The following is a description of a gene set: CD8+ T cells play a crucial role in the clearance of intracellular pathogens through the generation of cytotoxic effector cells that eliminate infected cells and long-lived memory cells that provide enhanced protection against reinfection. We have previously shown that the inhibitor of E protein transcription factors, Id2, is necessary for accumulation of effector and memory CD8+ T cells during infection. Here we show that CD8+ T cells lacking Id2 did not generate a robust terminally-differentiated KLRG1hi effector population, but displayed a cell-surface phenotype and cytokine profile consistent with memory precursors, raising the question as to whether loss of Id2 impairs the differentiation and/or survival of effector-memory cells. We found that deletion of Bim rescued Id2-deficient CD8+ cell survival during infection. However, the dramatic reduction in KLRG1hi cells caused by loss of Id2 remained in the absence of Bim, such that Id2/Bim double-deficient cells form an exclusively KLRG1loCD127hi memory precursor population. Thus we describe a role for Id2 in both the survival and differentation of normal CD8+ effector and memory populations. studied in species Homo sapiens Genes down-regulated in KLRG1 low CD8 T effector cells during infection: ID2 and BCL2L11 versus BCL2L11 knockout. from publication Knell J, Best JA, Lind NA, Yang E, D'Cruz LM, Goldrath AW (PMID 23325888) Human Gene Set: GSE41978_ID2_KO_AND_BIM_KO_VS_BIM_KO_KLRG1_LOW_EFFECTOR_CD8_TCELL_DN, and this is the list of marker genes: COL4A5, SRSF8, EPHX3, MTMR3, EHHADH, SLC6A16, AUTS2, AMIGO2, HBEGF, SYNE1, BRIP1, ZCCHC14, MYOM2, CNOT8, NHP2, ARRB1, DLEU1, SMOX, TUFT1, PPFIBP2 (NCBI Gene Id 8495), FZD2, PMCHL1, ATP2A2, TECPR2, DNASE1L1, IQSEC1, CBX7, F5, MARCKS, CHST3, PBX3, INAVA, BAZ2B, PFKFB3, RBM15, TLE1, CADM4, SIPA1L3, MZB1, MAVS, CROT, IARS1, EIF2AK1, POLH, ADGRG1, KLHL20, GNAT1, EHMT2, SERTAD2, PLAU (plasminogen activator, urokinase), TGFBR2, MRS2, SLC25A37, PRSS23, FAM171A1, USP34, ARL4A, RHD, ZNF672, JUND, SLC18A1, CUL3 (NCBI Gene Id 8452), CERK, GRB10, RHOBTB2, STAT5A, TRO, CCS, MYBL1, PELI2, DLG1, LEMD3, S100PBP, ZNF146, PPP1R3C, DNMBP, RAC1, TGFA, ZMIZ1, KBTBD11, CBL, TNFSF15, RASSF2, CTDSPL, TPX2, ENG, NSUN5, IRS2, FAN1 (NCBI Gene Id 22909), TNFRSF25, BMP1, MLLT11, TSC22D1, KIFBP, LUC7L2, HEY2, KERA, PNMA8A, AGAP1, MUC4, INPP5A, PALLD, IGFBP3, GPR37L1, TACC2, ZSCAN31, SLC22A7, NACC2, VPS72, KLF7, NFIB, SOX4, CASC3, NPEPPSP1, ZNF280A, CELP, MYO5C, GCKR, AGO2, CDC42EP3, CD86, ITGB5, CAMSAP1, TIPRL (NCBI Gene Id 261726), OTUB2, MYH10, SNX13, FOXO3, ST3GAL5, C2CD2, RRM2 (ribonucleotide reductase regulatory subunit M2), RNF139, F11R, EPAS1, KCTD17, PAGE1, SEPHS1, LPAR1, FOXRED2, LMCD1, CREB3L2, ABL1, EDA2R, GPRC5A, SMAGP, UBL3, C11orf68, HSPA12A, AP1S2, ZBED5, THSD7A, PDE8A, MPZL1, TRIM23 (NCBI Gene Id 373), RRN3, JAG2, PDZD8, SLC9A6, MARF1, MDH1, NUAK1, FAT1, TFAP2C, ODC1, SLC22A11, SPRY2, PPME1, MORC4, FLAD1, AGPAT5, NEDD9, MYH1, KANK2, DCLRE1A, TMF1, TRAK2, NR2F6, KCNF1, MEOX1 (NCBI Gene Id 4222), TPSG1, DPY19L1P1 (NCBI Gene Id 89231), SOCS5, RGS19, GET1, RBM23, ITGA10, ANKRD28, FOXD2, OSBP, EXTL1, RGR, DTL, ARB2A, FBXW11, ALKBH4, CYP2A13, CGRRF1, SDC4, CHST15